Given this list of marker genes ADGRD1, C2orf74, MGAT3 (beta-1,4-mannosyl-glycoprotein 4-beta-N-acetylglucosaminyltransferase), FOXQ1, LECT2, GIP, KCNJ14, C9orf50, NPAS2, UNCX, RAPGEF3, HPDL, FNDC4, EBF1, FGF16, KRT16, OPALIN, MFSD4B, SLAMF6, PRSS37, RAB40B, TRPC4, ELOVL2, SYN2, KXD1, CACNG8, FGD5, HIRA, KCNH2, PCDHB10, SLC4A9, C4orf33, MSANTD1, MYO15B, MDK, DKKL1, SLC8A2, PLA2G4F, CDH13 (cadherin 13), ARPP21, HAPLN4, SLC30A8, MXRA7, FOXA2, ANKRD7, AKAIN1, PRR9, C2orf88, FAM178B, SCUBE3, MAP6D1, NEXMIF, RAB3C, TPSB2, CD79A, PRDM5, PYGM, MYOZ3, DACT1, WDR17, ANO3, ANKRD29 (ankyrin repeat domain 29), LAMA2, SLC19A1, ITGB1BP1, CITED4, GP9, NTS, LSR, GKN1, CRYBA2, RASL12, TEKT4, NTRK1, FOXG1, LY6G6D, CDCA5, EFCAB9, VN1R5, DNAH2, FBXO2, MGARP, CACNA2D1 (calcium voltage-gated channel auxiliary subunit alpha2delta 1), SHD (Src homology 2 domain containing transforming protein D), SAA4, ERCC6L2, AMTN, POP1, C1QTNF2, BCAM, LURAP1L, PDZD4, DMD, TSPAN1, GLCCI1, MYL2, SRY, TSSK6, ZIC1, PLAC9, KRTAP3-3, LELP1, RARRES1, KCNJ15, CHST3, PDE6A, PECAM1, SH2D4B, IGDCC3, LARP6, POU2AF1, CAMK2N2, DDX25, PCSK5, KCNS1, FOXP3, KLHL10, HPCAL4, MFSD2B, BCO2, ZNF475, RBPJL, GPR15, ERMN, HPD, VEPH1, TSSK1B (NCBI Gene Id 83942), C1QTNF7, KCNH7, ITGA3, CHRNA5, GPRASP2, SELP, TOMM20L, TCHHL1 (trichohyalin like 1), PDZD2, FAM174B, RHBG, TET1, SPAG6 (sperm associated antigen 6), MEIOB, MYBPH, LARGE2, MRGPRX2, CYP17A1, LRRC71, ESR2, OR4E2, HOXB2, THBS4, MEIG1, RASSF9, HECW2, TMTC2, BHLHE23, CIB3, PDZRN4, TEX14, ADIG, IRX4, EXOC3L2, AMN, ATP1A4, RHD, MYOC, FBXO17, SOSTDC1, CHSY3, GRM8, PAX8, MCTP2, KRTAP4-7, ASIC3, SPATA46, SLC14A1, NETO2, KCND2, ZNF507, ALOX12B, ANKRD34B, PPP1R1A, TROAP, FOXB1, DGKK, CPN2, DLL3 (NCBI Gene Id 10683), ERICH6, CDHR1, GSTO2, SLC17A9, PDZRN3, FNDC7 (fibronectin type III domain containing 7), ACBD7, ATF7IP2, NOL3, FGF17, CDH23 (NCBI Gene Id 7395), PKP2, DAW1, SLC9B1, here is a description of the gene set: Genes down-regulated in B lymphocytes with MAP3K7 knockout: untreated versus anti IgM for 3h. studied in species Homo sapiens Human Gene Set: GSE41176_UNSTIM_VS_ANTI_IGM_STIM_TAK1_KO_BCELL_3H_DN The activation signaling of transcription factor nuclear factor-kB (NF-kB) plays central role for immune system. One of key kinase mediating this pathway is TAK1 in adaptive and innate immunity. However, role of TAK1 in B cell receptor signaling is still unclear. To know effects of TAK1-deletion on the gene expression induced by anti-IgM, we performed the time course analysis in comparison of wild type with TAK1-deleted splenic B cells. from publication Shinohara H, Behar M, Inoue K, Hiroshima M, Yasuda T, Nagashima T, Kimura S, Sanjo H, Maeda S, Yumoto N, Ki S, Akira S, Sako Y, Hoffmann A, Kurosaki T, Okada-Hatakeyama M (PMID 24833394)